Given this list of marker genes ENO2, GNS, SRGAP3, INPP5A, F11R, MIDEAS (mitotic deacetylase associated SANT domain protein), MICU3, LDLRAP1, BACH1 (NCBI Gene Id 571), TMEM74, F2R, GKAP1, MED12L, HOXB5, ZFP2, NREP, CAPS2, TMEM40, NRXN1, GALC, DSG2, FCER1A, ANKRD33B, EHBP1, ACOX1, UBL5, FRYL, RASGEF1B, P2RX1, ABHD18, SEMA7A, CPA3, NFE2, CPNE8, MMRN1, FGF11, TSC1, PAFAH2, PRKCA, GSTT1, PODXL, TMEM181, PRKAA2, BAHCC1, MAMDC2, GNG11, ZNF329 (zinc finger protein 329), DIP2C, RND2, PALLD, COL4A1, UPP1, PLCB1 (NCBI Gene Id 23236), PTGS1 (prostaglandin-endoperoxide synthase 1), PITPNC1, ITGA2B, IFT43, CYP7B1, CDK17, FHL1, CTNND1, INHA, GARRE1, SPRED2, TTLL7, NUCB1, NDRG2, NBEA, FAM110C, CDK10, TRPC6, SKIL, TTC39B, SPIN4, SCARF1, ZNF43, CDCP1, GPRIN2, FAM174B, FGD5, OCRL, LYSMD1, UBA7 (ubiquitin like modifier activating enzyme 7), RGS1 (regulator of G protein signaling 1), MUC13, PLXDC2, FAM110B, DMWD, USP54, CBR3, PLSCR4, SLC16A12, MPZL1, SLC16A9, MEG3, GBX2, NMT2, NDN, LHCGR, TLE6, RASSF6, HSD3B7, FGF3, RUNX1T1, PBX1, PITPNM1, ANKRD63, TEK, MBLAC2, CDKN1C, IRAK3, FKBP9, KLF12, CHMP4B, SLC6A15, ARHGAP29, RNF144B, CAVIN3, C9orf152, COL4A2, MKRN1 (NCBI Gene Id 392799), MYCN, RMDN1, FRY, DYNLT3, ALOX12, FOXJ2, PKIA, ST3GAL1, TMT1A, PBX3, SLC48A1, PRKG1, MID2, MYOM1, PHLDB2, DIAPH1, GIMAP5, GHR, CBX7, HACD4, SERPINB9, SGCE (sarcoglycan epsilon), SALL2, ICA1, PABPC4L, SMAGP, EXTL3, UBE2E2, MYCT1 (MYC target 1), PSTPIP2, NR3C2, CTNNAL1, BGN, MAGED2, CILK1, TRAF1, CADM1, MARVELD2, PDZK1IP1, TXNIP, MAF, LRRC36, ESAM, TRIB3, PER3, ITGB3, CALML4, VAMP8, GULP1, PEX26, CSGALNACT1, TRIM47, ETS2, TMEM140, AJUBA, MPL, FSTL1, NRK, TIE1, HAPSTR1, ARAF, YAF2, SMUG1, PHC3, DEPTOR, WBP1L, SHROOM4, TGM2, SIPA1L1, CCDC85B, INSIG1, CLN3, HSPA12B, SLC9B2, ADAM22, PLD1, H1-0, ITSN1, C6orf141, here is a description of the gene set: Human Gene Set: GSE21670_STAT3_KO_VS_WT_CD4_TCELL_IL6_TREATED_DN STAT3, an essential transcription factor with pleiotropic functions, plays critical roles in the pathogenesis of autoimmunity. Despite recent data linking STAT3 with inflammatory bowel disease, exactly how it contributes to chronic intestinal inflammation is not known. Using a T cell transfer model of colitis we found that STAT3 expression in T cells was essential for the induction of both colitis and systemic inflammation. STAT3 was critical in modulating the balance of T helper 17 (Th17) and regulatory T (Treg) cells, as well as in promoting CD4+ T cell proliferation. We used chromatin immunoprecipitation and massive parallel sequencing (ChIP-Seq) to define the genome-wide targets of STAT3 in CD4+ T cells. We found that STAT3 bound to multiple genes involved in Th17 cell differentiation, cell activation, proliferation and survival, regulating both expression and epigenetic modifications. Thus, STAT3 orchestrates multiple critical aspects of T cell function in inflammation and homeostasis. species: Homo sapiens from publication Durant L, Watford WT, Ramos HL, Laurence A, Vahedi G, Wei L, Takahashi H, Sun HW, Kanno Y, Powrie F, O'Shea JJ (PMID 20493732) Genes down-regulated in CD4 T cells treated with IL6: STAT3 knockout versus wildtype.